Given this list of marker genes GPX2, ARPC1B, RPL37A, CSF1, SLC31A1, ALAD, CPQ, PRXL2B, TUFT1, TMEM68, ERH, MARCO, LSM7, SMAP2, PACC1, H1-2, ATRAID, SOWAHC (NCBI Gene Id 65124), PLAUR, CDK1, DCTPP1, CENPC, NUF2, ENO2, B4GALT6, FAM107B, TBC1D8, NFAT5, CARD19, SLC25A33, GATB, ROCK1, MMD (NCBI Gene Id 23531), RIOX2, WAC, DDX24, SEMA4A, DNAJB4, VASN, SPIC, HGSNAT, MAP7, IL10RA, EBAG9 (NCBI Gene Id 9166), CLEC6A, SH3BGRL2, IL4I1, NFU1, COIL, DUSP6, TRIM44, RPS29, SCAMP5, HNMT, DCAF8, OST4, FERMT3, SAT1, CX3CR1, KCNN4, MCM7, ST6GAL1, SLC35A5, HEXIM1, KLC1, SEC24D, DOCK7, DNAJC15, TRAF1, AZIN1, ABCC10 (ATP binding cassette subfamily C member 10), RPLP0, SPSB3, WDR36, SYNCRIP, THRAP3, MAGOH, IK, GPR65, LACTB, WDR46, PLCG2, PF4, NEDD9, ALG9, B3GALNT1, PPP4R2, CD200R1, GRK6, SH3YL1, SNX14, RUVBL2, SCHIP1, DARS1 (aspartyl-tRNA synthetase 1), KICS2, ZFP36L1, AIM2, PLXND1, CD28, RBBP8, MRPL19, CD86, ZBTB22, MOSPD2, UTP11, WNK4, HP1BP3, WSB1, METTL5, ARMC7, RNF121, CBX5, TRAPPC2L, GRB10, SEPHS2, CD300C, TEX101, STK10, IRX3, MKNK1, LPCAT1, SPCS2, GNA12, NT5C, IPO9, CDKN2B, SLC11A2, SLC4A7, OTULINL, FNBP1, CAMK1D, PEX3 (NCBI Gene Id 8504), MRPS7, ADAMTS4, TEC, LCP1, COL4A2, IL12B, DUSP1, LOXL2, ADAM17, TPRA1, SLC29A1, PSMD7, TNC, SLC25A10, RRP15, PTGS1, TCF12, MAP4, OXSR1, IFNGR1, TPM2, FLNB, FAU (NCBI Gene Id 55430), LIG1, SLC13A3, CPSF1, CLEC4D, FAM32A, MXI1, TM9SF1, PDLIM5, ATP5MC2, NLRP5 (NCBI Gene Id 126206), RPL22, RPS7, MPST, DHX40, POLR1A, EIF2S1, OAT, PPFIBP2, SH3BP5L, ENC1, COMP, DDX49, ADGRA3, RBMXL1, HSD17B4, RAB3GAP2, SRSF3, SSR1, CLEC4A, LSM3, HACD3, RPS6KC1, TLR6, CAMP, TAGLN (NCBI Gene Id 6876), TMEM131L, HELLS, FIG4, CTBP2, VPS28, MAN1A1, PSMB5, MEF2C, MECR, PHACTR2, here is a description of the gene set: Human Gene Set: GSE22935_WT_VS_MYD88_KO_MACROPHAGE_24H_MBOVIS_BCG_STIM_DN Nitric oxide (NO) produced by macrophages (MØs) is toxic to both host tissues and invading pathogens and its regulation is therefore essential to suppress host cytotoxicity. MØ arginase 1 (Arg1) inhibits NO production by competing with NO synthases for arginine, the common substrate of NO synthases and arginases. Two signal transduction pathways control Arg1 expression in MØs. First, a MyD88-dependent pathway induces Arg1 in intracellular infections, while a second Stat6-dependent pathway is required for Arg1 expression in alternativelyactivated MØs. We found that mycobacteria-infected MØs produce soluble factors that induce Arg1 in an autocrine-paracrine manner via Stat3. We identify these factors as IL-6, IL-10 and GCSF. We further establish that Arg1 expression is controlled by the MyD88-dependent production of IL-6, IL-10 and G-CSF rather than cell intrinsic MyD88 signaling to Arg1. Our data reveal the MyD88-dependent pathway of Arg1induction following BCG infection requires Stat3 activation and may result in the development of an immunosuppressive niche in granulomas due to the induced Arg1 production in surrounding uninfected MØs from publication Qualls JE, Neale G, Smith AM, Koo MS, DeFreitas AA, Zhang H, Kaplan G, Watowich SS, Murray PJ (PMID 20716764) Genes down-regulated in macrophages 24h after M. bovis BCG infection: wildtype versus MYD88 knockout. studied in species Homo sapiens